Given this list of marker genes Zc3h8, Smyd3, Pou5f1, Rxra, Ncoa2, Hsf1, Hsf2, Vax1, Vax2, Tbx1, here is a description of the gene set: species: Mus musculus Mouse Gene Set: GOMF_RNA_POLYMERASE_II_INTRONIC_TRANSCRIPTION_REGULATORY_REGION_SEQUENCE_SPECIFIC_DNA_BINDING Binding to an RNA polymerase II intronic DNA sequence that regulates the transcription of the transcript it is contained within.